The following is a description of a gene set: part of: Metabolism of steroids Reactome Pathway: Metabolism of steroid hormones electronically inferred by orthology from the curated human pathway studied in species Mus musculus This event has been computationally inferred from an event that has been demonstrated in another species.<p>The inference is based on the homology mapping from PANTHER. Briefly, reactions for which all involved PhysicalEntities (in input, output and catalyst) have a mapped orthologue/paralogue (for complexes at least 75% of components must have a mapping) are inferred to the other species., and this is the list of marker genes: Cyp17a1, Srd5a1, Hsd3b4 (hydroxy-delta-5-steroid dehydrogenase, 3 beta- and steroid delta-isomerase 4), Pomc, Stard3nl, Fdx1, Hsd3b9, Akr1b7, Akr1b8, Hsd3b2, Hsd17b3 (NCBI Gene Id 15487), Fdx2, Hsd3b5, Hsd17b2, Sts, Cga, Cyp11b2, Hsd17b11, Hsd11b2, Hsd3b8, Hsd17b14, Fdxr, Serpina6, Akr1b1, Tspo, Stard3, Cyp19a1, Akr1b10, Hsd17b1, Tspoap1, Srd5a2